Given this list of marker genes Wwtr1, Fat4, Lif, Acat1, Stat1, Nphs2, Aqp1, Sox8, Pkd1, Hes1, Calb1, Adipoq, Lamb2, Wnt7b, Pdgfb, Pou3f3, Pax8, Slc22a6, Umod, Slc22a1, Pax2, Sox9, Osr1, Yap1, Lgr4, Hes5, Pkd2, here is a description of the gene set: The process whose specific outcome is the progression of the metanephric nephron epithelium over time, from its formation to the mature structure. An epithelium is a tissue that covers the internal or external surfaces of an anatomical structure. The metanephric nephron epithelium is a tissue that covers the surface of a nephron in the metanephros. Mouse Gene Set: GOBP_METANEPHRIC_NEPHRON_EPITHELIUM_DEVELOPMENT studied in species Mus musculus